Given this list of marker genes Map2k3, Rps27a, Ezh2, Jun, Map2k6, Mink1, Trp53, Map2k7, Rbbp4, Mapk3, Rbbp7, Fos, Cdkn2b, Mapk14, Kdm6b, Txn1, Mapk8, Mapkapk5, Mapk11, Map2k4, Mapk9, Ubb, Cdk4, here is a description of the gene set: part of: Cellular Senescence Reactome Pathway: Oxidative Stress Induced Senescence electronically inferred by orthology from the curated human pathway This event has been computationally inferred from an event that has been demonstrated in another species.<p>The inference is based on the homology mapping from PANTHER. Briefly, reactions for which all involved PhysicalEntities (in input, output and catalyst) have a mapped orthologue/paralogue (for complexes at least 75% of components must have a mapping) are inferred to the other species. studied in species Mus musculus